The following is a description of a gene set: The process in which a cell becomes capable of differentiating autonomously into a glial cell in an environment that is neutral with respect to the developmental pathway. Upon specification, the cell fate can be reversed. Human Gene Set: GOBP_GLIAL_CELL_FATE_SPECIFICATION studied in species Homo sapiens, and this is the list of marker genes: PAX6, NKX2-2, NFIA, NFIB, ASCL1, OLIG2, SOX9